Given this list of marker genes RAD51C, PDE11A, TP53, PTCH1, PTEN, PRKAR1A, RABL3, CDKN2A, PALLD, SMAD4, BRCA2, PALB2, KRAS, BRCA1, here is a description of the gene set: studied in species Homo sapiens Ovarian carcinoma A malignant neoplasm originating from the surface ovarian epithelium. Human Gene Set: HP_OVARIAN_CARCINOMA